Given this list of marker genes PDGFB, PDGFD, EGR1, ITGB3, IL6R, SERPINB7, CFLAR, here is a description of the gene set: species: Homo sapiens Human Gene Set: GOBP_POSITIVE_REGULATION_OF_GLOMERULAR_MESANGIAL_CELL_PROLIFERATION Any process that increases the frequency, rate or extent of glomerular mesangial cell proliferation.